Given this list of marker genes Egf, Csk, Src, Egfr, Grb2, Tgfa, Epgn, Pxn, Areg, Btc, Pik3r1, Hbegf, Ptpn11, Ereg, Gab1, Pik3ca, Pag1 (phosphoprotein associated with glycosphingolipid microdomains 1), here is a description of the gene set: Mouse Gene Set: REACTOME_GAB1_SIGNALOSOME GAB1 signalosome species: Mus musculus